Given this list of marker genes Lclat1, Hadha, here is a description of the gene set: Reactome Pathway: Acyl chain remodeling of CL part of: Glycerophospholipid biosynthesis This event has been computationally inferred from an event that has been demonstrated in another species.<p>The inference is based on the homology mapping from PANTHER. Briefly, reactions for which all involved PhysicalEntities (in input, output and catalyst) have a mapped orthologue/paralogue (for complexes at least 75% of components must have a mapping) are inferred to the other species. electronically inferred by orthology from the curated human pathway studied in species Mus musculus